Given this list of marker genes Epor, Jak2, Creb1, Epo, Kit, Stat5b, Nanog, here is a description of the gene set: Any process that results in a change in state or activity of a cell or an organism (in terms of movement, secretion, enzyme production, gene expression, etc.) as a result of an erythropoietin stimulus. Erythropoietin is a glycoprotein hormone that controls erythropoiesis. studied in species Mus musculus Mouse Gene Set: GOBP_RESPONSE_TO_ERYTHROPOIETIN